Given this list of marker genes NPR2, MSX2 (NCBI Gene Id 8053), PLCB1, STRA8, MSX1, MEIOSIN (NCBI Gene Id 388553), here is a description of the gene set: Any process that starts the inactive process of meiosis. Human Gene Set: GOBP_ACTIVATION_OF_MEIOSIS studied in species Homo sapiens